Given this list of marker genes MRPL58, ARHGAP31, MYCBP2, CISD2, TMPO, ACAT1, PCNA, TP53INP1, RNF141, MIS18A, ARHGAP11A, RLIG1, C22orf39, AKR1E2, NUDCD2, DRG1, FAM120C, EPS15L1, NHERF2, CDCA5, PLEKHA8, UNG, INSR, AURKB, PIAS3, C1QBP, OGFRL1, SASH3 (SAM and SH3 domain containing 3), ZDHHC14, ZDHHC3, PDLIM2, AMACR (NCBI Gene Id 23600), TUBA1B, CDT1, ZNHIT2, HNRNPUL2, ACTN1, MRNIP, LRWD1, MMD (monocyte to macrophage differentiation associated), CCAR2, RFX5, AVEN, TBL1XR1, OXLD1, C2CD5, IFT140, ENPP4, NRROS, BNIP3L, SNX9, KCTD14, GSG1, S1PR4, CPOX, TCF7L2, TRAPPC1 (trafficking protein particle complex subunit 1), BRWD3, MAT2B, FAM78A, RTTN, SLC37A3, GINS4 (NCBI Gene Id 84296), TTF2, SORL1, BCL7A, DOCK7, RABGAP1L, RUNDC3B, GALNT4, LIX1L, PTPN20, MAN1C1 (mannosidase alpha class 1C member 1), GPHN, RIPOR2, ZRANB3, SLC6A6, EZH2, FAM217B, CCR5, CDC7, STK24, DNAJB6, ENC1 (ectodermal-neural cortex 1), MPPE1, EID1, NCEH1, ZNF362, LAMTOR1, CENPU (NCBI Gene Id 79682), SLCO3A1 (NCBI Gene Id 28232), NXN, B3GALT5 (beta-1,3-galactosyltransferase 5), C4orf46, LRRCC1, ATAD2, DCAF7, SEPTIN10, CLSPN, RREB1, NOA1, PPM1H, ATG3, SPATA13, BBS9, AP4M1, TOR1A, SERBP1, FRA10AC1, UBASH3B (NCBI Gene Id 84959), MCM5, PSMG2, CEP57L1, HELLS, CDPF1, LYRM9, ASPM, MFSD3, PTK2, CSF2RB, TMED1, MRPL51, TIMD4, TTC3, FAM107B, SFI1, EME1, CD81, FIRRE, UQCC3, CDKN2D, WDR7, NDFIP1 (NCBI Gene Id 80762), PPP3CA, GMNN, RNF125, PARPBP, CCND1, LRRK1, PRKAR2B, DEPDC1B, ANGPTL2, WDR11, PIP4P1, EBAG9 (estrogen receptor binding site associated antigen 9), TTC32, ANKRD28, CKS2, DCAF8, SNAP47, MEGF8, BRAT1, HDHD3, RRM2, DGLUCY, MOGS, DDHD2, AP1S2, NUP210, DNA2, CSF1R, ZDHHC15, GPR171, BLOC1S5, ZNF512, PNPO, MBTPS2, ELOVL5, SLC4A7, HIRIP3, CMTM7, RTN1, POT1, KIT, MXD4, BLM, FIGNL1, CYB5A, NSMCE1, PPCDC, SLC46A3, SNAI3, CYLD, SEPHS1, DLX1, GPR34, ATM, ORMDL1, PDS5B, SPART, PANX1, HJURP, PRC1, TRAF3IP3, NCAPD3, MN1, CPSF1, TRIM14, PTEN, here is a description of the gene set: TCF-1 is an HMG family transcription factor which is known to be activated by the canonical Wnt signaling pathway and modulated by other signals such as those derived from T cell receptor. We found that during CD8 T cell responses, TCF-1 deficiency impaired long-term maintenance of antigen-specific memory CD8 T cells. We used microarrays to detect gene expression changes in memory CD8 T cells caused by TCF-1 deficiency. Genes down-regulated in memory CD8 T cells: wildtype versus TCF7 knockout. studied in species Homo sapiens from publication Zhou X, Yu S, Zhao DM, Harty JT, Badovinac VP, Xue HH (PMID 20727791) Human Gene Set: GSE20754_WT_VS_TCF1_KO_MEMORY_CD8_TCELL_DN